Given this list of marker genes PRMT1, EIF3B, HAT1, MRFAP1L1, ATIC, FEN1 (NCBI Gene Id 5882), MAGOH, CDK4, SMG7, UBAP2L, TOMM40, CYCS, CDC23, CCT5, UNG, VDAC1, SNRPA1, UTP3, MTHFD1, HSPA9, VBP1, GGCT, SSBP1, MRPL19, KPNA2, SCAMP3, LARP1, GSPT1, RAD23B, RNF126, SF3B2, EIF4G1, AHSA1, ALG8, HCCS, NSDHL, CCNB1, MFAP1, DDX1, HNRNPAB, NHP2, SOD1, G3BP1, RARS1, PPM1G, PSMD9, ACOT7, NAA10, HSPA4, here is a description of the gene set: Neighborhood of GSPT1 G1 to S phase transition 1 in the MORF expression compendium Human Gene Set: MORF_GSPT1 Neighborhood of GSPT1 studied in species Homo sapiens